Given this list of marker genes NFKB1, AMOT, PIK3CA, RAF1, TRIO, PDK1, RAC1, MAPK1, MAP2K6 (NCBI Gene Id 5608), MAP2K3, MTOR, YAP1, MAP2K5, GNAQ, MAP2K4, RHOA, MAP2K2, MAPK3, MAP2K1, AKT1, MAP2K7, here is a description of the gene set: Human Gene Set: WP_GNAQ_PATHWAYS_IN_PORTWINE_STAIN species: Homo sapiens GNAQ pathways in port-wine stain